Given this list of marker genes KIF20A, TNNI3, TRIM37, MYZAP (NCBI Gene Id 100820829), ACTC1, ALMS1, DOLK, FLNC, TNNT2, LAMP2, JPH2, PPA2, FKTN, MYH7, SERPINE1, RPL3L, PPP1R13L, MYL2, LMNA, MYPN, here is a description of the gene set: species: Homo sapiens Myocardial fibrosis is characterized by dysregulated collagen turnover (increased synthesis predominates over unchanged or decreased degradation) and excessive diffuse collagen accumulation in the interstitial and perivascular spaces as well as by phenotypically transformed fibroblasts, termed myofibroblasts. Myocardial fibrosis Human Gene Set: HP_MYOCARDIAL_FIBROSIS